Given this list of marker genes REL, ATP6V1F, NINJ1, CLEC7A, ARHGDIA, SNAP23, NABP1 (nucleic acid binding protein 1), ARPC5, CD14, CD86, ISG20, TMSB4X (NCBI Gene Id 7114), SPNS1, RNH1, ZFYVE16, C1orf162, TXNRD1, CTSS, PKIB, HLA-DQA1, COTL1, STK4, PCBP1, LY86, CD52, ATP5MF, SPAG9, TAPBP, MAP3K8, FNBP1, SNN, CD37, UBE2R2, THEMIS2, LDHA, FERMT3, RNASET2 (ribonuclease T2), MTPN, PPP1CA, ADA (NCBI Gene Id 100), PLIN2, CSTB, MSN, ANXA11, ATP1B3, HSPE1, POLR2L, YWHAZ, ARHGDIB, C1QA, CFP, HES4, ABL2, PSMB3, TNFRSF1B, ATP6V1H, H3-3A, KYNU, ANXA2, CLIC2, GPR137B, FCER1G, CAP1, PLEKHB2, LACTB (NCBI Gene Id 84943), SERF2, HM13, PLAUR, MS4A7, POLR2E, RIT1, TNFAIP8, MFSD1 (NCBI Gene Id 64747), RNF145, ISG15, MNDA (NCBI Gene Id 4332), MT-CO1, IL10RA, ATP13A3, BLOC1S1, CDC42 (NCBI Gene Id 998), CD63, PPP4C, TIMP1, IER3, CXCL2, TALDO1, MYO9B, SRGN, SEC11A, BAZ1A, RAB8A, BZW1, RALA, MGAT1, CD58, CTSD, DAZAP2, RNF181, CD1C, DSE (dermatan sulfate epimerase), AIF1, SSR4, FNIP2, CDC42SE1, PTPN1, VMO1, CASP1, NOP10, S100A4, NFKBIA, RGS2, RNASE6, HLA-DMB, TAGLN2, HLA-DRA, CYRIB, TUBB4B, HLA-DRB5, ABI1, TMEM9B, SPCS3, GRINA, GAPDH, LAMTOR2, WAS, CHCHD10, RGS1, FCGRT, CHMP4B, MIR22HG, COX5A, TRAPPC1, IL2RG, BTG1, IFNGR2, NCOA4, GNAI2, STX4, SDCBP (NCBI Gene Id 6386), FCGR2A, STMP1, MIR4435-2HG, ITGB2, CKLF, COPE, DUSP1, CXCR4, TYROBP, RHOG, CD68, IFNGR1, ATP6V0E1, NAPA, LYZ (lysozyme), CCR7, POMP, COX6B1, BID, LY96, ARPC2, CMTM6, CHMP1B, RBX1, ACOT9, DDX39A, TMEM167A, CARD16, TES, FKBP4, TPP1, HSP90AA1, ELF1, CTSH, BRI3, PPT1, CD74, MAP2K3, OSBPL8, ARL6IP5, HSPA6, HEXB, ATP6V1B2, MBP, CXCL16, RAB10 (NCBI Gene Id 51140), FCN1, CDC42EP3, RGCC, ARFGAP3, S100A10, ATP5MJ, SNX3, ACTB, CSTA, IFI30, HLA-C, CSF2RA, TMEM123, CDKN1A, CD83, HAVCR2 (NCBI Gene Id 84868), MOB1A, S100A11, CD53, CASP4, SOD2, FXYD5, HSPB1 (NCBI Gene Id 3315), FGR, WTAP, NEAT1, TPD52L2, LIMD2, LGALS3, TNIP1, CRIP1, STX11, SH3BGRL3, CORO1A (NCBI Gene Id 11151), BCL2A1, CNPY3, ATP6V0D1, COX7B, SLC16A3, YWHAH, RILPL2, IGSF6, LST1, PEA15, SFT2D1, PTPRE, SEC61B, COX8A, AURKAIP1, FTH1, PIM3, EVI2B, TSPO, AHR, LGMN, DNTTIP2, NDUFA13, B2M, HLA-DMA, TAOK3, GLIPR2, GNG5, ZEB2 (NCBI Gene Id 9839), SERPINB1, LMNA (lamin A/C), FCGR2B, GLIPR1, CFD, ATP5MK, PTP4A2, CAPZB, TYMP, PHACTR1, VAMP8, CPVL, FPR3, IL4I1, ACTR2, LGALS9, ENO1, PTPRC, CXCL8, TANK, NDUFB1, RNF13, SERPINA1, TXN, CEBPB, CFLAR, ACTR3, MYL6, NFKB1, VSIG4, TNFSF13B, HCLS1, GRN, MRPL18, VPS29, LPXN, HMOX1, PLEK, LAPTM5, SERPINB9 (serpin family B member 9), SPHK1, RGS10, PSME2, UPP1, ATP6V0B, OAZ1, SYNGR2, LAMTOR4, BNIP3L, FABP5, HLA-B, DBI, ARPC1B, TPM3, ARL8B, FTL, UBE2L3, PRDX1, LRRFIP1 (LRR binding FLII interacting protein 1), EVI2A, ARRB2, PPIF, HLA-A, CYTOR, HLA-DRB1, SQSTM1, CIB1, RNF130, CLEC10A, HMGA1, GRB2, M6PR, NPC2, YBX1, VASP, PKM, PSAP, GSTO1, ZFAND2A, MS4A6A, UBA52, BLOC1S2, ARPC4, CTSL, CD44, FLNA, SDS, CTSZ, CLIC1, NUMB, LIMS1, GPX1, ANXA1, PET100, BAX, ARF6, EMP3, ATF5 (NCBI Gene Id 22809), DOK2 (NCBI Gene Id 9046), ASAH1, JAML, MT-CO2, ANXA5, DPP7, GMFG, MPP1, GSTK1, CST3, NAA50, HSPA1A, GPSM3, PRR13, WIPF1, HLA-DQB1 (major histocompatibility complex, class II, DQ beta 1), MMP9, PDE4DIP, NDUFV2, CTSC, CALR, TMEM273, ARPC3, MAFB, PSMB9, FCER1A, CAPZA1, HLA-DPB1 (major histocompatibility complex, class II, DP beta 1), CYBA, INSIG1, ELOF1, RAP1A, PPP1R18, TUBA1C, BLVRB, MARCKS, MACROH2A1, LITAF (lipopolysaccharide induced TNF factor), OSTF1, AP2S1, CD48, ATP2B1, PYCARD, FGL2, C15orf48, EHD1, B4GALT1, PGK1, ARL4C, SAT1, CREM, AP1S2, LGALS2, OLR1, LAP3, CAPG, ZNF706, RAB8B, HCST, SAMSN1, ADRM1, GNA15, COX17, HSBP1, RAB5C, RBM47, G0S2, RAB7A, EZR, S100A6, CYTIP, GLA, UQCR11, CYRIA, RHOA, WARS1, CFL1, ATP6AP2, LSP1, CACYBP, ACAA1, GPX4, MAP2K1, PGLS, HLA-DPA1, JARID2, ETS2, PFN1, NAMPT, CORO1C, GPAT3, ATP5F1E, ALOX5AP, ABRACL, IQGAP1, GABARAP, CALHM6 (NCBI Gene Id 441168), CTSB (cathepsin B), LGALS1, BASP1, PABPC1, ATOX1, RAP1B, LCP1, ALDH2, AKAP13, SPI1, EFHD2, GPR183, S100A9, CDC37, here is a description of the gene set: studied in species Homo sapiens from publication Fan X, Bialecka M, Moustakas I, Lam E, Torrens-Juaneda V, Borggreven NV, Trouw L, Louwe LA, Pilgram GSK, Mei H, van der Westerlaken L, Chuva de Sousa Lopes SM (PMID 31320652) The ovaries analyzed showed a pronounced population of CD53high/CXCR4high immune cells (Fig. 2e), including separate clusters for adaptive T lymphocytes and Natural Killer (NK) cells (CL4 and CL12), B lymphocytes (CL18), and innate immune system, such as monocytes and macrophages (CL13) Human Gene Set: FAN_OVARY_CL13_MONOCYTE_MACROPHAGE